The following is a description of a gene set: studied in species Homo sapiens Abortive elongation of HIV-1 transcript in the absence of Tat Human Gene Set: REACTOME_ABORTIVE_ELONGATION_OF_HIV_1_TRANSCRIPT_IN_THE_ABSENCE_OF_TAT, and this is the list of marker genes: POLR2L, NELFE, GTF2F2, NELFA, POLR2F, POLR2K, NELFB, NCBP2 (nuclear cap binding protein subunit 2), SUPT5H, NCBP1, NELFCD, CTDP1, SUPT4H1, POLR2J, POLR2E, POLR2B, POLR2C, POLR2I, GTF2F1, POLR2A, POLR2D, POLR2G, POLR2H